Given this list of marker genes TNS3, MET, ITGB1, HGF, TNS4, here is a description of the gene set: part of: MET promotes cell motility studied in species Homo sapiens Interaction of MET with tensin protein TNS4 at focal adhesion sites promotes cell motility through and unknown mechanism. MET also interacts with TNS3, whose expression seems to be inversely correlated with TNS4. Reactome Pathway: MET interacts with TNS proteins